Given this list of marker genes Hras, Plce1, Cdc42, Tirap, Hacd3, Jak1, Cd81, Avpi1, Stat1, Ighm, Dusp16, Grb2, Jun, Muc20, Rab7b, Fos, Prkcb, Arhgap5, Stat3, Map3k1, Syk, here is a description of the gene set: To identify biomarkers that discriminate the aggressive forms of prostate cancer, we performed gene expression profiling of prostate tumors using a genetically engineered mouse model that recapitulates the stages of human prostate cancer, namely Nkx3.1; Pten mutant mice. We observed a significant deregulation of the epidermal growth factor and mitogen-activated protein kinase (MAPK) signaling pathways, as well as their major downstream effectors--the activator protein-1 transcription factors c-Fos and c-Jun. Forced expression of c-Fos and c-Jun in prostate cancer cells promotes tumorigenicity and results in activation of extracellular signal-regulated kinase (Erk) MAPK signaling. In human prostate cancer, up-regulation of c-Fos and c-Jun proteins occurs in advanced disease and is correlated with Erk MAPK pathway activation, whereas high levels of c-Jun expression are associated with disease recurrence. Our analyses reveal a hitherto unappreciated role for AP-1 transcription factors in prostate cancer progression and identify c-Jun as a marker of high-risk prostate cancer. This study provides a striking example of how accurate mouse models can provide insights on molecular processes involved in progression and recurrence of human cancer. Mouse Gene Set: OUYANG_PROSTATE_CANCER_PROGRESSION_UP from publication Ouyang X, Jessen WJ, Al-Ahmadie H, Serio AM, Lin Y, Shih WJ, Reuter VE, Scardino PT, Shen MM, Aronow BJ, Vickers AJ, Gerald WL, Abate-Shen C (PMID 18381418) Genes up-regulated during prostate cancer progression in mice heterozygotic for both NKX3.1 and PTEN. species: Mus musculus